The following is a description of a gene set: from publication Billmann-Born S, Till A, Arlt A, Lipinski S, Sina C, Latiano A, Annese V, Häsler R, Kerick M, Manke T, Seegert D, Hanidu A, Schäfer H, van Heel D, Li J, Schreiber S, Rosenstiel P (PMID 21335489) studied in species Homo sapiens NOD2 is an intracellular receptor for the bacterial cell wall component muramyl dipeptide (MDP) and variants of NOD2 are associated with chronic inflammatory diseases of barrier organs e.g. Crohn disease, asthma and atopic eczema. It is known that activation of NOD2 induces a variety of inflammatory and antibacterial factors. The exact transcriptomal signatures that define the cellular programs downstream of NOD2 activation and the influence of the Crohn-associated variant L1007fsinsC are yet to be defined. To describe the MDP-induced activation program, we analyzed the transcriptomal reactions of isogenic HEK293 cells expressing NOD2wt or NOD2L1007fsinsC to stimulation with MDP. Importantly, a clear loss-of-function could be observed in the cells carrying the Crohn-associated variant L1007fsinsC, while the NOD2wt cells showed differential regulation of growth factors, chemokines and several antagonists of NF-κB, e.g. TNFAIP3 (A20) and IER3. Genes up-regulated in HEK293 cells over-expressing wildtype NOD2: untreated versus muramyl dipeptide for 2h. Human Gene Set: GSE22611_UNSTIM_VS_2H_MDP_STIM_NOD2_TRANSDUCED_HEK293T_CELL_UP, and this is the list of marker genes: PSMA1, FOXJ3 (NCBI Gene Id 22887), RGS12, BCL7A, IDH3A, DGKE, GOLPH3, ZNF322P1, ARHGEF15, U2AF1, CNOT3, GTF2E1, CKAP2, STMN1, AQP8, MT2A, ELK4, DYRK1B, IL10RB, ETV7, GYG1, GREB1L, NPVF, CKM, GPKOW, GFRA2, RRAS2, LAMB3, GALNT11, NME5, HLCS, PKNOX2, CHN1, SULF1, RBM23, REPS1, PPAN, PLOD3, GLT8D1, UTP11, TROAP, CETN3, HGH1, GDF2, AHDC1, NRG1, UBE2E1, MED21, INO80B, SCAF11, PPP3CA, CEP15 (NCBI Gene Id 57415), DNM1L, TSBP1, KAT7, ZNF154, RAD54L2, IRS4, GFAP, HOXB8, PLLP, RFX7, DGKQ, EBP, TLN1, AP2B1, AGRP, AKR1B1, PSMA6, SKA1, SSBP1, MTMR14, KCNB1, BAZ2A, FGGY, ADAM8, SCNN1D, PHTF2, THSD7A, PIP5K1A, REPS2, CROT, GNA11, PLEK2, CBR4, ARID3A, NFIB, CYB5R3, STXBP1, TGFBR3, GNL3, HIP1, EPS8L2, TBX1, KLK5, ATP5PF, SP3P, LSM12, LILRA5, TCN1, TECPR2 (tectonin beta-propeller repeat containing 2), F11R, ATAD2, ABCE1, JMJD4, PLA2G5, ADGRV1, APOC2, CCT2, ICAM5 (NCBI Gene Id 7087), TCP10L3, IFNA1, OVGP1, ASCL3, SDC2, LEF1, CLSTN3, LILRB5, HNRNPM, IFI16, APOA4, TCERG1, PSRC1, SLC35B1, HCRT (NCBI Gene Id 3060), HDHD5, GRAPL-AS1, GHITM, CREBBP, DELEC1, ANGPT2, TRPV6, CLASRP, UCHL3, C3, CHRNA1, HMGB3, CTNND2, GRM4, TRIP12, MTMR11, RPS18, C11orf24, SKAP2, PFAS, ATP5PB, EIF2S1, PTPRD, MATCAP2, GATA2, INA (internexin neuronal intermediate filament protein alpha), PENK, ACSL1, GATM, ZNF217, JUNB, DCAF16, NLRP2, MAP3K11, CHRNA3, SH2B2, SNRPB2, POP4, GSK3A, NYX, HILPDA, MRPL46, FBXW11, FOXN1, GSK3B, PRDX4, QRSL1, DNAJA1, RAD21, SLC17A5, FCRL2, PPP3R1, UTP20, IFT46, RNF34, PSMC5 (proteasome 26S subunit, ATPase 5), FSTL1, PRAME, VPS37B, SLC19A3, HCG9, NPM1, HSD11B1, MBNL2, PGC, DMTN, ASPH, ACOX1 (NCBI Gene Id 8308), SLC7A1, CYP4F11, B4GALT2